Given this list of marker genes NFKBIA, MCL1, IER3, RAB1A (NCBI Gene Id 5861), MAP2K3, TNFRSF12A, KRT14, FUBP3, SDCBP, EWSR1, CYTH1, SYNCRIP, BCAR3, CCND1, KRT19, CD83, KLRC2, SRSF1, FUBP1, EFNA1, JUNB, NFE2L2, EGR3, FHL2, SGK1, CCN1, ELL2, SRSF5, NR4A1, TXNRD1, COL7A1, HNRNPH1, SERPINB5, PLK2, MFAP2, EPHA2, TRAF4, NFKB2, here is a description of the gene set: The infection of human cells by adenoviruses leads to a gradual reduction in the activity of host cell functions while viral gene expression progresses in a regulated way. We used the DNA microarray technique to determine the transcriptional activity profiles of cellular genes upon infection with adenovirus type 12 (Ad12). The microarray data were validated by quantitative real-time PCR for genes which showed significant alterations after Ad12 infection. At 12 h postinfection, there is a striking up-regulation between 10- and 30-fold in the expression of the G1P2, IFIT1, and IFIT2 cellular immune response genes compared to mock-infected cells. At later stages of infection, when the majority of regulated cellular genes has been turned down, a limited number of cellular genes exhibit increased activities by factors of 3 or less. These genes belong to the signal transduction or transcriptional regulator classes or are active in protein degradation, like ANPEP, an aminopeptidase. The SCD and CYP2S1 genes function in lipid metabolism. The eucaryotic translation initiation factor 4 is up-regulated, and one of the major histocompatibility complex genes is diminished in activity. For two of the genes, one up-regulated (CTSF gene) and one down-regulated (CYR61 gene), alterations in gene activity were confirmed at the protein level by Western blotting experiments. Increased genetic activity of cellular genes late in adenovirus infection has not been reported previously and demonstrates that Ad12 has a sustained control of host cell gene expression well into the late phase of infection. from publication Dorn A, Zhao H, Granberg F, Hösel M, Webb D, Svensson C, Pettersson U, Doerfler W (PMID 15681441) Human Gene Set: DORN_ADENOVIRUS_INFECTION_32HR_DN species: Homo sapiens Genes down-regulated in HeLa cells (cervical carcinoma) 32 h after infection with adenovirus Ad12.